The following is a description of a gene set: Mouse Gene Set: GOBP_MESENCHYMAL_STEM_CELL_MAINTENANCE_INVOLVED_IN_NEPHRON_MORPHOGENESIS studied in species Mus musculus The process in which an organism retains a population of mesenchymal stem cells that contributes to the shaping of a nephron. A mesenchymal stem cell is a cell that retains the ability to divide and proliferate throughout life to provide progenitor cells that can differentiate into specialized mesenchymal cells., and this is the list of marker genes: Bmp7, Hnf1b, Sall1, Pax8, Pax2, Six2, Wnt9b